Given this list of marker genes BAHD1, ZFYVE19, RNU6-354P, EIF4EBP2P2, RHOV, RNU6-610P, RPS3AP47, SPINT1-AS1, MIR626, GANC, MFAP1, CHST14, CCDC9B, PPIP5K1P1, CKMT1A, INO80, SPTBN5, KNL1, SNAP23, PLA2G4E, OIP5-AS1 (NCBI Gene Id 731273), VPS18, VPS39-DT, RN7SL487P, C15orf62, TMEM87A (transmembrane protein 87A), CCNDBP1, GCHFR, PLA2G4B (phospholipase A2 group IVB), SUMO2P15, MYL12BP1, MIR627, BUB1B, ENSG00000259617, RAD51, PLA2G4E-AS1, ZNF106, ITPKA (inositol-trisphosphate 3-kinase A), PPP1R14D, TTBK2, CHAC1 (ChaC glutathione specific gamma-glutamylcyclotransferase 1), TP53BP1, GOLM2 (NCBI Gene Id 113201), CATSPER2P1, PDIA3P2, BNIP3P5, MAPKBP1, TYRO3, EHD4, ANKRD63, RNU6-188P, OIP5, MIR1282, PLA2G4F, RN7SL497P, BMF-AS1, CTDSPL2, STRCP1, PIN4P1, RNU6-554P, RNA5SP393, SPCS2P1, TGM5, PLCB2, ELL3, TMEM62 (NCBI Gene Id 95722), RNU6-516P, GPR176-DT, PHGR1, ELOCP2, FRMD5, RPLP0P10, CAPN3, PAK6-AS1, BUB1B-PAK6, H3P38, LTK, UBR1, INO80-AS1, RPAP1, ENSG00000285080, CTDSPL2-DT, ATP5PDP1 (NCBI Gene Id 641557), SERF2, CCDC32, STRC, MAP1A (microtubule associated protein 1A), NUSAP1, NDUFAF1, GAPDHP43, RTF1, DNAJC17, CKMT1B, GPR176, RMDN3, KRT8P50, GAPDHP55 (NCBI Gene Id 100421324), KNSTRN, PAK6, PDIA3, ENSG00000260926, CDAN1 (codanin 1), VPS39, LRRC57, ACTBP7, RNU6-353P, RPUSD2, MGA, SPINT1, TUBGCP4 (tubulin gamma complex component 4), IVD, SERINC4, JMJD7, SRP14, TGM7, CYCSP2, CATSPER2, MAPDA, DISP2, EHD4-AS1, RNA5SP392, EIF2AK4, PLA2G4D, STARD9, JMJD7-PLA2G4B, PLCB2-AS1, ZSCAN29, RAD51-AS1, ENSG00000259584 (NCBI Gene Id 105370787), CIBAR1P1, BMF, EXD1, WDR76, MIR4310, SRP14-DT, TTBK2-AS1, EPB42, LCMT2, HAUS2, INAFM2, HYPK, DLL4, RN7SL376P, RNU6-1169P, ISCA1P4, HNRNPMP1, PPIP5K1, CHP1, FDPSP4, here is a description of the gene set: Human Gene Set: chr15q15 studied in species Homo sapiens